Given this list of marker genes EMILIN1, FBN1, FBN2, EMILIN3, TTN, FBLN2, EMILIN2, FBLN5, LAMC1, ELN, AHNAK, here is a description of the gene set: species: Homo sapiens The action of a molecule that contributes to the structural integrity of a complex or assembly within or outside a cell, providing elasticity and recoiling. Human Gene Set: GOMF_STRUCTURAL_MOLECULE_ACTIVITY_CONFERRING_ELASTICITY